The following is a description of a gene set: Genes predicted to be targets of miRBase v22 microRNA mmu_miR_421_3p in miRDB v6.0 with MirTarget v4 prediction scores > 80 (high confidence targets). species: Mus musculus from publication Chen Y, Wang X (PMID 31504780) Mouse Gene Set: MIR_421_3P, and this is the list of marker genes: Meis2, Larp4b, Foxo3, Msl2, Marf1, Pdgfra, Rbm41, Arb2a, Zfp169, Arid4b, Prpf19 (NCBI Gene Id 28000), Tesk2, Cd209b, Slc12a5, Mei4, Spmip3, Slc25a36, Oog1, Hhip, Gulp1 (NCBI Gene Id 73157), Dennd5b, Chrnb3, Rora, Exoc3, Kpnb1, Scn2a, Pcbp2, Sub1, Sh3rf1, Atosa, Psmd10, Hnrnpa1, 6030458C11Rik, Sbk1, Nckap1, Ccdc122, Tmcc3, Ttbk2, Dcaf10, Mgat4a, 4933434E20Rik, Tex261, Srr, Hipk3, Gkn1, Utp23, Ets1, Eif2s2, Srsf7, Tbx22, Eppk1, Atad2b, Ythdf1, Ube2b, Runx1t1, Scd1, Fchsd2, Dda1, Dusp16 (dual specificity phosphatase 16), Lrrc4, Trim27, Bambi, Nras, Ctdspl2, Sik3, Trmt2a, Trhr, Plcb1, Prelid3a, Srp9, Zfp148, Lrfn5, Strn3, Ywhah, Bach2, Ankrd13c, Ndfip1, Fgf10, Brd10, Ivns1abp, Ythdc2, Fbxl5, Rdx, Znrf3, Fut9, Cacnb4, Dlx3, Sp8, Fgd4, Zdhhc5, Iws1, Tcaim, Agmo, Stat1, Cul4b, Bclaf3, Pabir1, Rnmt, Prkaa2, Ppp2r2c, Atxn1, Ppp4r2 (protein phosphatase 4, regulatory subunit 2), B3galnt1, Il13ra1, Ric3, Ankrd17, Bmf, Sp3, Kras, Gas7, Sh3glb1, Msantd4, Far1, Chd7, Dnajc27 (NCBI Gene Id 319948), Atp6v1g3, Nap1l1, St3gal1, Ppig, Sema6d, Mtcl3, Ipo5 (NCBI Gene Id 97586), Qki, Capza1, Reps2, Snrnp70, Stx3 (NCBI Gene Id 20908), Rpgr, Zbtb11, Rabgap1l